The following is a description of a gene set: Genes down-regulated in germinal center T helper cells compared to other CD4+ T lymphocyte types. Gene expression profiling was used to compare the gene expression patterns of human germinal center (GC) T helper (Th) cells with other CD4+ T-cell subsets (naive, central, and effector memory T cells). GC-Th cells, specifically localized in germinal centers to help B cells, are distantly related to central and effector memory T cells in global gene expression profiles. GC-Th cells displayed substantial differences in mRNA for adhesion molecules, chemoattractant receptors, and cytokines compared with other populations. Distinct expression of transcriptional factors by GC-Th cells is consistent with the hypothesis that they may be different from other T cells in cell lineage. Interestingly, CXCL13, a critical chemokine for B-cell entry to lymphoid follicles, is one of the most highly up-regulated genes in GC-Th cells. GC-Th cells (but not other T cells) produce and secrete large amounts of functional CXCL13 upon T-cell receptor activation, a process that is dependent on costimulation, requires translation and transcription, and is dramatically enhanced by activation in the presence of GC-B cells. This study revealed for the first time the unique gene expression program of GC-Th cells. from publication Kim CH, Lim HW, Kim JR, Rott L, Hillsamer P, Butcher EC (PMID 15213097) Human Gene Set: KIM_GERMINAL_CENTER_T_HELPER_DN species: Homo sapiens, and this is the list of marker genes: SPTBN1, RAP1GAP2, IRS2, ACSM2A, DHRS3, OSBP, ZNF331, ELL2, DUSP8, PER1, RORA, S1PR1